The following is a description of a gene set: studied in species Mus musculus Any process that modulates the frequency, rate or extent of protein folding. Mouse Gene Set: GOBP_REGULATION_OF_PROTEIN_FOLDING, and this is the list of marker genes: Pdcl3, Pdia3, Grn, Dnajb2, Bag5, Pdcd5-ps, Pdia4, Pdcd5, Hspa8, Pofut2, St13, Pdcl